Given this list of marker genes PLN, RAP1GDS1, RAMP3, EDN1, EDNRA, RAC1, CDC42, here is a description of the gene set: studied in species Homo sapiens An G protein-coupled receptor signaling pathway which contributes to a circulatory system process carried out by the heart. Human Gene Set: GOBP_G_PROTEIN_COUPLED_RECEPTOR_SIGNALING_PATHWAY_INVOLVED_IN_HEART_PROCESS